Given this list of marker genes IRF6, IER3IP1, DNASE1L3, ANKRD34C, ZNF682, GGA1, LARGE1, HYDIN, MCM2, HLA-DRA, SYK, CD80, UGDH (UDP-glucose 6-dehydrogenase), ZNF536, KCTD20, OBI1, YBX3, DRAM1, SOCS5, RHOBTB1, MKLN1, MYEF2, ITGB3, SBNO1, WWOX, HAUS5, SMPX, CPB1, CD19, KYNU, RPS27, PARG, TGFBR1, IGHM, CHAT, FZD10, IDI2-AS1, TRMT2B, DPF3, AP1G1, SMAD5, BLNK, MYOZ3, KRT19P2, MTCL2, HLA-DMA, PARM1, GPM6A, KLHL35, PTPRK, GPATCH2L, FPR2, MOXD1, CLCN4, ZNF532, IL24, BCL11A, GSTA4, ATP6V0A1, POU2AF1, PPM1D, SLC35F2, KATNBL1, RAD51D, HLA-DMB, BET1, GATM, VAV3, TLL1, PRPH2, MAP1B, GALNT3, TIAM2, TOMM34, GRK3, PDE10A, TSHB, IQCB1 (IQ motif containing B1), MAGEA3, CYP4B1, PDLIM1, CLEC4A, SLC9A7, TFPI2, TCL1A, SLC4A4 (solute carrier family 4 member 4), PIP5K1B, ZC3H7B, MYO1E, PEG10, MPZL1, STRN3, ZNF821, CD200, TSPAN13, CD79B, MCTP2, BTK, TNS3, PTGS1, LINC00339, RMI1, PLCG2, MYO1B, GTPBP2, IRF4, USP2, SCD5, DPPA4, LHFPL2, MTMR9, WEE1, CPEB3, IRF8, SLC6A16, CDK14, TULP2, TCF4, COLEC10, MROH9, ATXN3, RIC3, UST, BANK1, PPEF2, SPOCK1, MED14OS, FMO5, NIPSNAP3B, ZNF552, CNR2, RIPOR1, ENTPD1, SPRING1, HMGCS1, SETBP1, HLA-DQB1, CD22, CEP43, ZNF235, CNR1, HHEX, NEBL, MTMR10, GSTA1, NOD1, FAM30A, SERPINB5, TMOD1, TBC1D12, PHTF1, NEK4, MIR600HG, GTPBP3, GABBR1, MS4A1, HLA-DPB1, DCAF17, ADAM19, SOBP, DDR1, RRAS2, EHD3, H4C4, LY86, POLR1HASP, RADX, FBXO4, TRIO, TREML2, SLC2A5, CR2 (complement C3d receptor 2), FRAS1, UTP14C, HLA-DRB1, HILPDA, SEMA4F, FMO3, TIMELESS, EVI5, COLEC12, CTNNAL1, CCP110, CHL1, CD72, ZNF468, CORO2B, SLC15A3, DTX4, PHLPP2, HDAC9, MARCHF3, GM2A, HESX1, MEF2C, TSPYL5, here is a description of the gene set: Genes down-regulated in comparison of naive CD4 T cells versus naive B cells. from publication Abbas AR, Baldwin D, Ma Y, Ouyang W, Gurney A, Martin F, Fong S, van Lookeren Campagne M, Godowski P, Williams PM, Chan AC, Clark HF (PMID 15789058) Human Gene Set: GSE22886_CD4_TCELL_VS_BCELL_NAIVE_DN Immune cell-specific expression is one indication of the importance of a gene's role in the immune response. In order to identify such patterns, we set out to broadly profile gene expression in a variety of immune cells. studied in species Homo sapiens